Given this list of marker genes Lrtm2, Snrk, Mdm2, Acvr1, Slc25a46, Ermp1, Nqo2, Aak1, Eya3, Gpr35, Trank1, Mdm1, Fam222b, Lasp1, Stard3, Phactr2, Fam171a1, Pex12, Stat3, Nob1 (NCBI Gene Id 67619), Tmem181a, Tnc, Ago1, Ube2g1, Slc6a2, Cpsf2, Tnrc6b, Spata31d1c, Gpatch8, Armc3, Spast, Slc26a5, Bnc2, Mdn1, Slc16a10, Wrnip1, Rit1, Col3a1, Slc38a9, Tln2, Tmem260, Bsn, Ndufa10, Jph3 (NCBI Gene Id 57340), Rdh12, Tspan2, Ocrl, Colgalt1, Ptp4a1, Abraxas2, Lnx1, Eif3b, Grpel1, Slc27a2, Cdkl4, Zfp644, Marchf9, Casp7, Cyp7b1, Grin3a, Arsj, Lrrc17, Orc3, Chgb (NCBI Gene Id 12653), Elavl3, Tbx20, Med1, Cep350, Loxl2, Tecrl, Adcyap1r1, Dazap2, B3gnt7, Uty, Mecp2, Tmem196, Zfhx3, Snx2, Gpd2, Btd, Fbxl17, 4931406C07Rik, Rwdd3, Fsbp, Ubqln4, Igf2bp3, Nr4a3, Npas3, Rad9a (RAD9 checkpoint clamp component A), Cyp1a1, Lgals1 (NCBI Gene Id 16852), Luzp1, here is a description of the gene set: Genes predicted to be targets of miRBase v22 microRNA mmu_miR_5623_3p in miRDB v6.0 with MirTarget v4 prediction scores > 80 (high confidence targets). species: Mus musculus Mouse Gene Set: MIR_5623_3P from publication Chen Y, Wang X (PMID 31504780)